Given this list of marker genes THSD7B, ARSB (arylsulfatase B), PNP, IVD, CHST6, CSPG4, THSD4, FMO3, CYP27B1, ADAMTS17, DLD, ADAMTSL2, ADAMTSL4, DCN, CYP2U1, CSF2RB, ADAMTS6, SDC4, GALNT12, MUC16, PPP1R3C, FDXR, G6PC1, ALG6, GYG2, GNS, DPAGT1, POMT1, MPDU1, HEXB, PMM2 (NCBI Gene Id 5373), B4GALT1, GCLC, GCLM, ARG1, MCCC2, GGT1, CPS1, AHCY, HPRT1, CD320, MUC1, IDH1, RPIA (NCBI Gene Id 22934), BCKDK, SLC37A4, POMT2, FDX1, ALG12, CYP7B1, ABCA3, CYP21A2, GALK1, SEMA5B, GFPT1, DHDDS, ALG11, GPC1 (glypican 1), ADAMTSL5, HEXA, LARGE1, LUM, MUC3A, PPM1K, GPC4, GPC3, THSD1, MUC2, LMBRD1, CYP19A1 (NCBI Gene Id 1588), DOLK (dolichol kinase), OPLAH, MUC15, THBS1, SRD5A3, MAT1A, GALNT3, B3GLCT, MUC6 (mucin 6, oligomeric mucus/gel-forming), DAG1, ADAMTS10, PGM1, GPC6, GALNS, MMUT, UBB, RFT1, NOTCH4, MTR, MUC21, RPS27A, ASS1, ABCD4, NAGLU, HLCS, CYP1B1, MUC19, GYS1 (NCBI Gene Id 2997), TCN2, MUCL1, SPON2, EXT1, SLC25A15, BTD, ALG14, ALG1, ADAMTSL3, ALG13, SGSH, GPC2, MMAA, CSPG5, GBE1, ADAMTS3, MUC5AC, CBLIF, SI, POMC, NEU1 (neuraminidase 1), MTRR, SEMA5A, B3GAT3, NCAN, MCCC1, G6PC3, PC, CYP27A1, GUSB, SFTPA1, GALT, DBT, ADAMTS2, ALG3, SDC2, OMD, MUC4, NOTCH3, NOTCH1, HIBCH, MOGS, ADAMTS12 (NCBI Gene Id 81792), FDX2, CUBN, DPM3, ACACA, PAPSS2, CYP26C1, KERA (keratocan), CYP2R1, MMACHC, GSS, ECHS1, ADAMTS13, SDC3 (NCBI Gene Id 9672), MPI, GLB1, ADAMTS14, PCCA, UBC, NUS1, CYP11B1, DCXR, MUC20 (mucin 20, cell surface associated), BCKDHA, CYP17A1, HYAL1, CSF2RA, IDUA, ST3GAL3, SFTA3, MUC13, CFP, ADAMTS19, GALM, AMN, MAOA, MUC3B, CYP11A1, NAGS, BCAN, ASL, ACAT1, TPMT, CTSA, IDS, SBSPON, ADAMTS9, CYP26B1, FMOD, UGT1A4, SFTPB, UBA52, TBXAS1, KHK, OGN, MAN1B1, ADAMTS4, SLC35D1, ALG8, B4GAT1, CHST3, SLC26A2, BCKDHB, ACY1, SLC34A2, SDC1, MUC12, MUC5B, ADAMTSL1, THSD7A, ACAN, GYS2, THBS2, SPON1, NHLRC1, CHST14, C1GALT1, MMAB, UGT1A1, SSPOP, MC2R, ADAMTS16, C1GALT1C1, ALDOB, APRT, EXT2, MUC7, LFNG, HGSNAT, NOTCH2, ADAMTS7, AUH, CHSY1, CYP4F22, OTC, PRELP, MMADHC, HSPG2, MGAT2, ADAMTS1, ADAMTS20, CYP24A1, PAH (NCBI Gene Id 5053), POMGNT1, DPM1, GPC5, DPM2, B4GALT7, MUC17, SFTPA2, ADAMTS15, GYG1, TALDO1, ADAMTS8, ADA, ADAMTS18, GALE, PCCB, EPM2A, SFTPC, CYP11B2, LCT, GAA, SFTPD, AGRN, ADAMTS5, BGN, ALG9, ALG2, GNE, VCAN (NCBI Gene Id 7902), NMRAL1 (NCBI Gene Id 57407), B3GALT6, here is a description of the gene set: Metabolic processes in human cells generate energy through the oxidation of molecules consumed in the diet and mediate the synthesis of diverse essential molecules not taken in the diet as well as the inactivation and elimination of toxic ones generated endogenously or present in the extracellular environment. Mutations that disrupt these processes by inactivating a required enzyme or regulatory protein, or more rarely by changing its specificity can lead to severe diseases. Metabolic diseases annotated here involve aspects of carbohydrate, glycosylation, amino acid (phenylketonuria), surfactant and vitamin metabolism, and biological oxidations. One somatic mutation that affects cytosolic isocitrate metabolism, often found in glioblastomas and some lymphoid neoplasms, is also annotated. Also described are mutated forms of adrenocorticotropic hormone (ACTH) that can lead to obesity, resulting in excessive accumulation of body fat. Reactome Pathway: Diseases of metabolism part of: Disease species: Homo sapiens